Given this list of marker genes RARB, ESRRA (estrogen related receptor alpha), HNF4G, THRA, PPARA, NR2F1, VDR, PPARG, NR3C2, NR1D2, NR2E3, NRBP1, ESR2, NR1D1, NR5A2, RORA, RORC, NR4A3, NR2E1, PGR, NR1H2, NR6A1, THRB, NR5A1, RXRG (NCBI Gene Id 6258), RARA, NR4A2, NR1I2, NR2C2, PPARD, NR1I3, ESR1, AR, NRBF2, RXRA, MED1, HNF4A, RARG, RORB, NCOR1, NR2C1 (nuclear receptor subfamily 2 group C member 1), NR0B2, ESRRG, RXRB, NR0B1, NR3C1, NR2F6, NR2C2AP, NR1H3 (NCBI Gene Id 113429), ESRRB (estrogen related receptor beta), NCOR2, NR1H4, NR4A1, here is a description of the gene set: Nuclear Receptor transcription pathway studied in species Homo sapiens Human Gene Set: REACTOME_NUCLEAR_RECEPTOR_TRANSCRIPTION_PATHWAY